The following is a description of a gene set: Reactome Pathway: Creatine metabolism In humans, creatine is synthesized primarily in the liver and kidney, from glycine, arginine, and S-adenosylmethionine, in a sequence of two reactions. From the liver, creatine is exported to tissues such as skeletal muscle and brain, where it undergoes phosphorylation and serves as a short-term energy store. The mechanism by which creatine leaves producer tissues is unclear, but its uptake by consumer tissues is mediated by the SLC6A8 transporter.<P>Once formed, phosphocreatine undergoes a slow spontaneous reaction to form creatinine, which is excreted from the body. species: Homo sapiens part of: Metabolism of amino acids and derivatives, and this is the list of marker genes: CKB, GAMT, CKMT1A, SLC6A8, SLC6A11, GATM, SLC6A12, SLC6A7, CKMT2, CKM